The following is a description of a gene set: Negative regulation of the PI3K/AKT network species: Homo sapiens Human Gene Set: REACTOME_NEGATIVE_REGULATION_OF_THE_PI3K_AKT_NETWORK, and this is the list of marker genes: FGF19, PIK3AP1, EREG, GAB1, KL (klotho), PIP5K1A, PIK3CG, PHLPP1, FLT3LG, AKT2, PIK3R3, IRS2, FGF1, PDGFRA, PPP2CA, NTRK2, SRC, MET, FLT3, AREG, NRG2, CD86, IRS1, NTRK3, FGFR3, CD80, TRAT1, ERBB3, NRG1, PDGFB, NTF3, PTEN, PPP2R1A, TGFA, IRAK4, EGF, PIK3R1, FGF7 (fibroblast growth factor 7), AKT1, FGF6, ICOS, AKT3, FGFR4, PPP2R5A, FGF3, ERBB2, STRN, FYN, PIP5K1B, FGF9, GAB2, VAV1, FGF8 (fibroblast growth factor 8), GRB2, THEM4, PDGFA, NRG4, IER3, EPGN, PDGFRB, IL1RL1, INS, PPP2R5B, FGF5, RHOG, PIK3R2, LCK, PTPN11, NRG3, MAPK1, KLB, CD28, PPP2R5D, ERBB4, FGF20, FGF18, FGFR2, FGF23, FGF17, ESR1, IRAK1, PPP2R5C, TRIB3, PPP2R5E, PIK3CB, PPP2R1B, EGFR, PIP4K2A, FGF10, PIK3CD (phosphatidylinositol-4,5-bisphosphate 3-kinase catalytic subunit delta), KIT, BTC (betacellulin), CD19, HGF, PIP4K2C, BDNF, PIP5K1C, INSR, FGF16 (fibroblast growth factor 16), IL1RAP, PIK3R5, FRS2 (NCBI Gene Id 10818), IL33, RAC2, MYD88, HBEGF (heparin binding EGF like growth factor), FGF4, FGF2, PPP2CB, PHLPP2, MAPK3, FGF22, RAC1, PIK3CA, NTF4, PIP4K2B, TRAF6, ESR2, KITLG, PIK3R6, FGFR1